The following is a description of a gene set: Genes predicted to be targets of miRBase v22 microRNA mmu_miR_764_3p in miRDB v6.0 with MirTarget v4 prediction scores > 80 (high confidence targets). from publication Chen Y, Wang X (PMID 31504780) species: Mus musculus Mouse Gene Set: MIR_764_3P, and this is the list of marker genes: Nectin3 (NCBI Gene Id 72384), Gab2, Stra6l (STRA6-like), Mymx, Pcid2, Zhx3, Nkd1, Xirp2, Tmem236, Lin7c, Xrcc3, Stmn4, Pde6g, Atp8b4, Phf21a, Card10, Cdyl2, Kcnj5, Pmfbp1, Lmo1, Mllt1, Acaca, Fam161a, Them5, Srsf2, Nat8f2, Celf2, Cdk20, Smim24, Mark1, Cyp2f2, Eefsec, Mvb12b, Actn4, Onecut2, Mafk, Neu1, Igf1, Vps37c, Cxcl12, Shisa7, Fndc4, Tgm6, Hip1, Abhd4, Fam83f, Kdm4b, Atp2a2, Zfp426, Agpat4, Erc1, Xirp1, Hacd1, Oaf, Epha2, Xkr5, Mindy4, Tbc1d24, Adamts2, Zfp92, Lrfn4, Sorbs3, Spag17, Clrn1, Rnf38, Sprn, Arhgef17, Pax2, Tsbp1, Rnf130, Tbc1d14, Kdm2a, Herc6, Fam181a, Lelp1, Ago3, Chd2, Ankrd54, Aak1, Gga1, Adam19, Stat3 (NCBI Gene Id 68733), Muc1, Mrpl15, Loxl4